Given this list of marker genes CASP4, ospC3, UBC, ipaH9.8, GBP3, CALM2, UBE2D2, GBP2, GBP1, CALM3, RPS27A, nleF, CALM1, UBB, GBP6, UBA52, GBP4, here is a description of the gene set: part of: Infection with Enterobacteria Specifically, Shigella flexneri secretes OspC3, which catalyzes ADP-riboxanation of CASP4, thereby inhibiting its catalytic activity and blocking lipopolysaccharide (LPS)-induced pyroptosis (Kobayashi T et al., 2013; Li Z et al., 2021; Hou Y et al., 2023). Pathogenic Escherichia coli strains secrete the T3SS effector NleF, which directly binds and inhibits CASP4 as well as apoptotic caspases CASP8 and CASP9 (Blasche S et al., 2013). The crystal structure of the NleF:CASP9 complex revealed a novel inhibitory mechanism involving insertion of the NleF carboxy-terminus into the protease active site (Blasche S et al., 2013). Bacterial NleF blocks CASP4 activation in vitro and also inhibits CASP4 during enteropathogenic (EPEC) or enterohemorrhagic (EHEC) infection in epithelial cells (Pallett MA et al., 2017; Song T et al., 2017). During EPEC infection, NleF suppresses CASP4 activity and CASP4-dependent interleukin-18 (IL-18) processing (Pallett MA et al., 2017). studied in species Homo sapiens Reactome Pathway: Enterobacterial factors antagonize host defense